Given this list of marker genes Apoc2, Prkcd, Apoc1, Idh1, Apoc2l, Scarb1, Ldlr, Enpp7, here is a description of the gene set: Any process that modulates the rate, frequency, or extent of phospholipid catabolism, the chemical reactions and pathways resulting in the breakdown of phospholipids, any lipid containing phosphoric acid as a mono- or diester. species: Mus musculus Mouse Gene Set: GOBP_REGULATION_OF_PHOSPHOLIPID_CATABOLIC_PROCESS